Given this list of marker genes Pitx2, Bmp4, Ctnnb1, Mecom, Rspo2, Alx3, Dicer1, Chd7, Twist1, Trp63, Lmbr1, Lrp6, Smarca4, Rpgrip1l, Alx4, Fgf4 (NCBI Gene Id 14175), Pitx1, Gnas, Msx2, Gpc3, Notch1, Tbx3, Wnt7a, Msx1, Rarb, Aff3, Osr2, Shh, Zbtb16, Rarg, Wnt3 (wingless-type MMTV integration site family, member 3), Fgf8, Tbx4, Med1, Osr1, here is a description of the gene set: studied in species Mus musculus Mouse Gene Set: GOBP_EMBRYONIC_HINDLIMB_MORPHOGENESIS The process, occurring in the embryo, by which the anatomical structures of the hindlimbs are generated and organized. The hindlimbs are the posterior limbs of an animal.